The following is a description of a gene set: Binding to a small nucleolar RNA. Human Gene Set: GOMF_SNORNA_BINDING studied in species Homo sapiens, and this is the list of marker genes: IMP4, DKC1, UTP25, SNU13, NUDT5, BYSL, NOP14, NUDT16L1, TBL3, NOP56, WDR3, NUDT16, UTP6, ISG20 (interferon stimulated exonuclease gene 20), PRKDC, DDX21, XRCC5, NHP2, TSR1, NUDT4, NOP10, NUFIP1, BMS1, GAR1, NUDT7, DHX37, NOP58, HEATR1 (HEAT repeat containing 1), RRP9, SDE2, NUDT1, IMP3